Given this list of marker genes PLIN2, PNPLA2, CHKA, PRKAA1, PLIN3, PRKAA2, KAT5, here is a description of the gene set: Human Gene Set: GOBP_LIPID_DROPLET_DISASSEMBLY The disaggregation of a lipid particle into its constituent components. studied in species Homo sapiens